The following is a description of a gene set: species: Mus musculus The series of molecular signals initiated by the binding of a ligand (such as a bacterial peptidoglycan) to a cytoplasmic nucleotide-binding oligomerization domain containing 1 (NOD1) protein receptor, and ending with regulation of a downstream cellular process. Mouse Gene Set: GOBP_NUCLEOTIDE_BINDING_OLIGOMERIZATION_DOMAIN_CONTAINING_1_SIGNALING_PATHWAY, and this is the list of marker genes: Nfkbia, Tlr4, Slc15a4, Peli3, Tnfaip3, Xiap, Nod1, Ripk2, Slc46a2